Given this list of marker genes TMEM8B, STAMBP, SYNJ2BP, SLAMF7, TIPIN, DNM3OS, TSSK4, FXYD7, BBS12, LINC00662, MAMDC2, ARSB, UGT2B17, MGARP, ZNF358, GPR34, AKAP13, RNF122, RTL5, LINC03007, PGBD4, RPS27L, VANGL1, LRRC14, TCF20, SGSM2, SNHG16 (small nucleolar RNA host gene 16), ZBTB24, TAX1BP3, FILIP1, C19orf44, PCDH11X, INPP5B, IGFL1, SPRR4, ZNF432 (NCBI Gene Id 9668), TRIM17 (NCBI Gene Id 51127), KRTAP2-4, CST9L, LINC02591, GPATCH4, KIF27, ANG, LINC00900, ACE, RBCK1, BPHL, NNMT, PLIN5 (NCBI Gene Id 440503, perilipin 5), MAP7D3, RTKN2, DND1, ENSG00000293232, ZNF780B, MOGAT1, EML5, IL27RA, DZIP1L, ITGAV, BBS4, SORT1, GADD45GIP1, PLPP1, FLACC1, S100A2, SRPRB, ECHDC1, SOST, GS1-600G8.3, AFDN, CEBPB, TMPRSS3, NHERF1, PKD2L2, LPCAT1, ISCA2, SMIM10, MLLT3, CD300A, TP53I11, ARHGAP29, CPO, ID3, C1orf115, GIMAP1, LRRK1, CHST13, LDOC1 (NCBI Gene Id 93489), EPB41L3, FAM216B, GPR85, ZNF417, AIFM3, SYT17, AOAH, DVL1, DYNC2LI1, IL5, FKBP1B, NPL, ZFPM1, HOXC9, NPFF, TAS2R39, COL2A1, C2CD4A, CABS1, RECQL4, IL18BP, CHST11 (NCBI Gene Id 55807), NCKAP1, TFEC, PCED1A, TMEM106A, WDFY3, TMA16, IFIT1, TSEN54, IL1RL2, DENND2C, DOCK8-AS1, LINC01711, ZNF436-AS1, SVIP, AARS2, GALNT11, E2F6, GSTT1, KCNJ2-AS1, GGA2, SERPINF2, DNASE1 (deoxyribonuclease 1), ANKRD40, GVQW3, CEACAM21, KMT2A (lysine methyltransferase 2A), NPHP3, ITGA3, TMPO-AS1, LYRM2, MDC1, UCN, LINC02145, PNMA8A, TRIM39, ZSCAN16, MGAT4D, TRAM2-AS1, KRT222, EMC6, KIAA0586, CLPS, CYRIA, RAD21L1, COA3, NR5A1, TPCN1, NHERF4, FPR2, HELQ, MGAT5, TPTEP1, GJA9, TAB1, RTBDN, SMCR5, A1BG, AMPD3, ABI3BP, ARL4D, CD300LD-AS1, GABRP, KLF4, TRBV24-1 (T cell receptor beta variable 24-1), CORO1C, PBX4, ABCA8, NKX3-1, RFC2, NDUFB7, SLC6A14, PLIN2, GLG1, UBE2Q1, PLXDC2, BLVRB, RHBDD3, here is a description of the gene set: from publication Marigo I, Bosio E, Solito S, Mesa C, Fernandez A, Dolcetti L, Ugel S, Sonda N, Bicciato S, Falisi E, Calabrese F, Basso G, Zanovello P, Cozzi E, Mandruzzato S, Bronte V (PMID 20605485) studied in species Homo sapiens Human Gene Set: GSE21927_GMCSF_IL6_VS_GMCSF_GCSF_TREATED_BONE_MARROW_UP Tumor growth is associated with a profound alteration of myelopoiesis, leading to recruitment of immunosuppressive cells known as myeloid-derived suppressor cells (MDSCs). Analyzing the cytokines affecting myelo-monocytic differentiation produced by various experimental tumors, we found that GM-CSF, G-CSF, and IL-6 allowed a rapid generation of MDSCs from precursors present in mouse and human bone marrow (BM). BM-MDSCs induced by GM-CSF+IL-6 possessed the highest tolerogenic activity, as revealed by the ability to impair the priming of IFN- -producing CD8+ T cells upon in vivo adoptive transfer. Moreover, adoptive transfer of syngeneic, GM-CSF+IL-6-conditioned MDSCs to diabetic mice transplanted with allogeneic pancreatic islets resulted in long term acceptance of the allograft and correction of the diabetic status. Cytokines inducing MDSCs acted on a common molecular pathway. Immunoregulatory activity of both tumor-induced and BM-derived MDSCs was entirely dependent on C/EBP transcription factor, a key component of the emergency myelopoiesis triggered by stress and inflammation. Adoptive transfer of tumor antigen-specific CD8+ T lymphocytes resulted in therapy of established tumors only in mice lacking C/EBP in myeloid compartment. These data unveil another link between inflammation and cancer and identify a novel molecular target to control tumor-induced immune suppression. We used gene expression analysis to identify those factors, secreted by tumor-infiltrating MDSC, which could drive emathopoiesis. Moreover we compare gene expression profile of tumor-induced MDSC, obtained from either the spleen and the tumor infiltrate of tumor bearing mice, and in vitro bone marrow-derived MDSC. Genes up-regulated in CD11b BoneMarrow from BALBc mouse incubated with GMCSF and IL-6 versus CD11b BoneMarrow from BALBc mouse incubated with GMCSF and GCSF.